The following is a description of a gene set: Human Gene Set: GOMF_C_ACYLTRANSFERASE_ACTIVITY Catalysis of the transfer of an acyl group to a carbon atom on the acceptor molecule. studied in species Homo sapiens, and this is the list of marker genes: HADHA, ACAT1, SPTSSA, SPTLC1, SCP2, ACAA2, ACSM2B, ACSM2A, ACAA1, ACSM1, ACSM3, GCAT, SPTLC3, HADHB, SPTLC2, ACSM5, ACAT2, SPTSSB, ACSM6, ACSM4